The following is a description of a gene set: species: Homo sapiens CXCR4-GNB/G-PLCB-PKC signaling pathway. Pathway ID: N00413. Pathway type: Reference. Pathway class: nt06167 Human cytomegalovirus (HCMV). Human Gene Set: KEGG_MEDICUS_REFERENCE_CXCR4_GNB_G_PLCB_PKC_SIGNALING_PATHWAY Pathway Definition from KEGG: CXCL12 -> CXCR4 -> GNB/G -> PLCB -> (Ca2+,DAG) -> PKC -> PTK2B -> (PTK2+BCAR1+CRK+PXN), and this is the list of marker genes: PXN, PTK2B, GNG13, GNG3, PLCB1, GNG2 (G protein subunit gamma 2), CXCL12, GNGT1, GNG10, GNB2, GNB3, PRKCB, PLCB4, BCAR1, PRKCG, PLCB2, PTK2, GNG5, CXCR4 (NCBI Gene Id 93405), GNG11, GNG12, GNB1, GNB4, GNG4 (G protein subunit gamma 4), PLCB3, GNG7, GNB5 (G protein subunit beta 5), GNG8, GNGT2, CRK, PRKCA